The following is a description of a gene set: species: Homo sapiens Any process that activates or increases the frequency, rate, or extent of interferon-beta production. Human Gene Set: GOBP_POSITIVE_REGULATION_OF_INTERFERON_BETA_PRODUCTION, and this is the list of marker genes: TLR3, ISG15, IRF1, OAS2, POLR3B, POLR3D, TOMM70, POLR3F (NCBI Gene Id 115527), ZC3HAV1, OAS1, STING1, DHX9, HMGB1, DDX3X, RIGI, IRF7, IRF3, POLR3G, TLR4, RIOK3, IRF5, TRIM56, RNF135, FLOT1, TLR2, TLR7, OAS3, PTPN11, ZBTB20, POLR3A, TLR8, TLR9, TRIM65, MAVS, TBK1, TICAM1, RIPK2, IFIH1, HSP90AA1, ARRDC4, POLR3C, HMGB2